The following is a description of a gene set: species: Homo sapiens Genes having at least one occurrence of the motif NNNWAAAYAAAYANNNNN in the regions spanning 4 kb centered on their transcription starting sites. This matches the FOXJ2 transcription factor binding site V$FOXJ2_01 (v7.4 TRANSFAC). Human Gene Set: FOXJ2_01, and this is the list of marker genes: DMD, ARTN, CSRNP3, ANGPTL1, RAB3IP, NEUROD2, ZBTB20, BAMBI, OTX2, ANGPT1, MITF, HOXC4, PRR34, CPEB4, POGZ, RORA, NSG2 (NCBI Gene Id 51617), NRG1, CHCHD7, NCDN, FAM72A, NTF3, ORC4, SSH3, SKIDA1, BRCA2, FBXL22, GAP43, TYRO3, HESX1, MEF2C, DTNA, CEND1, CYP26B1, LGI1, BRIP1, TWIST1, ACP6, SCUBE3, MGLL, C12orf57, TRERF1, NECTIN1, ADGRB3, RGMA, SLIT3, FOXN1, CDAN1, NEO1, CILK1, NCAM1, EGR2, CYRIA, HNF4A, FOXP2 (NCBI Gene Id 93986), HSF2, KLF3-AS1, CDH10 (NCBI Gene Id 1008), NREP, NFIB (nuclear factor I B), TLE4, FOXB1, KCNK10, TNF, FGF9, PRDM1, ZBTB37, GRM3, ACACA, PCDH17, ID1, COL13A1, SLN, SCAMP1, HOXA7, SLC44A1 (NCBI Gene Id 63942), PRKAG1, LTA, POLR3F, PABIR1, ESRRG, TSPAN17, PIK3C2A, IL17C, IRS4, CRH, IFNA5, KRT84, TBXAS1, CREB5, PHTF2, PPP1CB, BCL11B, CELF4, GOLGA1, PKIA, FSTL1, TGFB2, HAND2, RTL9, GNAO1, KLF3, CLDN8, PLAG1, PDE7A, TSPYL2, ATXN7L1, IL25, RUNX2, PTF1A, PTGR3, SLC39A8, CNTLN, DRD3, PRMT6, CTNNAL1 (catenin alpha like 1), LINC03122, MSL3, HOXA11, TRPS1, IMPDH1, SOX6, RBFOX1, FLOT1, LUC7L, BDH1, SLC35C2, SUPT4H1, HOXA10, IER3, ATP2A2, E2F5, STX5, GFI1, PREX2, NTN1, SLITRK2, CXCL2, C1orf43, CPNE1, GNAZ, MSTN, TWIST2, SCML1, C6orf136, CH25H, DOCK3, TNR, GFRA1, HOXC6, FEN1, NOVA1, PCF11, BUB1, ATP1B4, UBR1, HEY2, PPM1D, LINC00474, RGS6, PLEC, FBXO11, IFNA10, HMCN1, SLC10A7, SCG3, KLF12, UCKL1, TMEM258, STOML2, LCP2, DAAM1, ID2, CD68, ERRFI1, ARHGAP30, IFNA17, REST, CHN2, CUX1, KCTD15, DNAJB12, RPS6KB1, ZHX2 (zinc fingers and homeoboxes 2), BUB3, FABP4, LUC7L3